Given this list of marker genes SOX5, DNAI7, LRRC23, CLEC12B, ACRBP, LINC02366, RASSF8, GSG1, GPRC5D-AS1, H2AJ, PLCZ1, ATF7IP, CAPZA3, here is a description of the gene set: Human Gene Set: KORKOLA_SEMINOMA_DN from publication Korkola JE, Houldsworth J, Chadalavada RS, Olshen AB, Dobrzynski D, Reuter VE, Bosl GJ, Chaganti RS (PMID 16424014) Genes from the 12p region that were down-regulated in seminoma tumors compared to normal testis. species: Homo sapiens Adult male germ cell tumors (GCTs) comprise distinct groups: seminomas and nonseminomas, which include pluripotent embryonal carcinomas as well as other histologic subtypes exhibiting various stages of differentiation. Almost all GCTs show 12p gain, but the target genes have not been clearly defined. To identify 12p target genes, we examined Affymetrix (Santa Clara, CA) U133A+B microarray ( approximately 83% coverage of 12p genes) expression profiles of 17 seminomas, 84 nonseminoma GCTs, and 5 normal testis samples. Seventy-three genes on 12p were significantly overexpressed, including GLUT3 and REA (overexpressed in all GCTs) and CCND2 and FLJ22028 (overexpressed in all GCTs, except choriocarcinomas). We characterized a 200-kb gene cluster at 12p13.31 that exhibited coordinated overexpression in embryonal carcinomas and seminomas, which included the known stem cell genes NANOG, STELLA, and GDF3 and two previously uncharacterized genes. A search for other coordinately regulated genomic clusters of stem cell genes did not reveal any genomic regions similar to that at 12p13.31. Comparison of embryonal carcinoma with seminomas revealed relative overexpression of several stem cell-associated genes in embryonal carcinoma, including several core stemness genes (EBAF, TDGF1, and SOX2) and several downstream targets of WNT, NODAL, and FGF signaling (FGF4, NODAL, and ZFP42). Our results indicate that 12p gain is a functionally relevant change leading to activation of proliferation and reestablishment/maintenance of stem cell function through activation of key stem cell genes. Furthermore, the differential expression of core stem cell genes may explain the differences in pluripotency between embryonal carcinomas and seminomas.